Given this list of marker genes AMIGO1, MYOCD, ZFHX2, ENOSF1, BDNF, LRTOMT, SLC25A42, RAB1B, TCOF1, HDAC7, SLC41A2, HLA-G, GAPVD1, CASTOR2, RANBP10, COTL1, TMEM11, HLA-DQB2, PRR14L, LYRM4, DBH, PCDHB9, SMG5, PRX, LMOD1, RBM43, PELI3, ZGPAT (zinc finger CCCH-type and G-patch domain containing), RPTOR, GNAS, SNRPD3, STK38, ZNF275, MEF2D, NREP, ALPK3, TNN, MOCS1, GEM, MLEC, PARVA, ANTXR2, NFATC3, PAPPA2, NOVA2, PTPRN, EPHA8, LHX8, BCL7A (NCBI Gene Id 605), PITPNM2, DDR1, ELAPOR2, EDAR, CISD1, AIG1, ATG2A, TSPAN3, CD2, ZBTB4, TGM2, KCTD15, AGO1, YWHAH, STMN2, SLC6A8, HOOK3, CYB5R3, DDX17, CABP2, TMEM178B, DCN, CTDSP1, HAX1, GLP2R, RAB11FIP1, PTPN23, CACNA1E, MTSS1, WDR82, XIRP1, KIF17, DIRAS1, NTRK2, IRS1, PDIA6, TSPAN9, GUCA2B, CPLX4, JPH4, SLC6A17, MRAS, LRFN2, MGLL, THOC7, LENEP, DLK1, LSM12, SUPT16H, PPP1R1B, ITM2C, here is a description of the gene set: from publication Chen Y, Wang X (PMID 31504780) Genes predicted to be targets of miRBase v22 microRNA hsa-miR-654-5p in miRDB v6.0 with MirTarget v4 prediction scores > 80 (high confidence targets). studied in species Homo sapiens Human Gene Set: MIR654_5P